Given this list of marker genes Ramp1, Mapkapk3, Ly6a, Cpeb2, Ppp1r13b, Foxo3, Tec, Dnajb4, Ltb, Plin2, Nol4l, here is a description of the gene set: Genes with promoters bound by FOXP3, dependent on it, and down-regulated in hybridoma cells stimulated by PMA and ionomycin. Foxp3+CD4+CD25+ regulatory T (T(reg)) cells are essential for the prevention of autoimmunity. T(reg) cells have an attenuated cytokine response to T-cell receptor stimulation, and can suppress the proliferation and effector function of neighbouring T cells. The forkhead transcription factor Foxp3 (forkhead box P3) is selectively expressed in T(reg) cells, is required for T(reg) development and function, and is sufficient to induce a T(reg) phenotype in conventional CD4+CD25- T cells. Mutations in Foxp3 cause severe, multi-organ autoimmunity in both human and mouse. FOXP3 can cooperate in a DNA-binding complex with NFAT (nuclear factor of activated T cells) to regulate the transcription of several known target genes. However, the global set of genes regulated directly by Foxp3 is not known and consequently, how this transcription factor controls the gene expression programme for T(reg) function is not understood. Here we identify Foxp3 target genes and report that many of these are key modulators of T-cell activation and function. Remarkably, the predominant, although not exclusive, effect of Foxp3 occupancy is to suppress the activation of target genes on T-cell stimulation. Foxp3 suppression of its targets appears to be crucial for the normal function of T(reg) cells, because overactive variants of some target genes are known to be associated with autoimmune disease. Mouse Gene Set: MARSON_FOXP3_TARGETS_STIMULATED_DN from publication Marson A, Kretschmer K, Frampton GM, Jacobsen ES, Polansky JK, MacIsaac KD, Levine SS, Fraenkel E, von Boehmer H, Young RA (PMID 17237765) species: Mus musculus